Given this list of marker genes RBM8A, FGFR3, B2M, CILK1, FGF23, RECQL4, CHST3, SHOX, CCN2, RNU4ATAC, RSPO2 (R-spondin 2), MBTPS2, TBX5, TRPV4, KDELR2, VPS35L, FGFR2, POR, LBR, NPR2, COL2A1, FLNB, PCNT, FLNA, IHH, MMP13, SERPINF1, PRKG2, IFT43, ROR2, SLC26A2, KIAA0753, GDF5, HOXA11, P3H1, GNPNAT1 (NCBI Gene Id 64841), TRIP11, B3GALT6, COL11A1, GLI3, SPARC, WNT7A, SP7, SCARF2, RIPK4, LAMA5, TMEM67, here is a description of the gene set: Bowing of the arm A bending or abnormal curvature affecting a long bone of the arm. studied in species Homo sapiens Human Gene Set: HP_BOWING_OF_THE_ARM